The following is a description of a gene set: Under normal physiological conditions, a disintegrin and metalloproteinase with thrombospondin type 1 repeats 13 (ADAMTS13) downregulates VWF procoagulant activity by cleaving the peptide bond between Tyr1605 and Met1606 within the A2 domain of VWF in a shear-dependent manner. Deficiencies in ADAMTS13 activity results in defective cleavage of ultra large VWF multimer in the plasma and are associated with excessive thrombi formation in the microvasculature in patients with thrombotic thrombocytopenic purpura (TTP) (Zheng XL 2015; Sukumar S et al. 2021). TTP is caused either by inherited mutations in the ADAMTS13 gene or by acquired inhibitory autoantibodies directed against the ADAMTS13 protein. part of: Defects of platelet adhesion to exposed collagen Reactome Pathway: Defective VWF cleavage by ADAMTS13 variant species: Homo sapiens, and this is the list of marker genes: COL1A1, COL1A2, VWF, ADAMTS13